The following is a description of a gene set: Genes correlated with the development of hyperglycemia in obese mice. from publication Nadler ST, Stoehr JP, Schueler KL, Tanimoto G, Yandell BS, Attie AD (PMID 11027337) species: Mus musculus Obesity is strongly correlated with type 2 diabetes mellitus, a common disorder of glucose and lipid metabolism. Although adipocytes are critical in obesity, their role in diabetes has only recently been appreciated. We conducted studies by using DNA microarrays to identify differences in gene expression in adipose tissue from lean, obese, and obese-diabetic mice. The expression level of over 11,000 transcripts was analyzed, and 214 transcripts showed significant differences between lean and obese mice. Surprisingly, the expression of genes normally associated with adipocyte differentiation were down-regulated in obesity. Not all obese individuals will become diabetic; many remain normoglycemic despite profound obesity. Understanding the transition to obesity with concomitant diabetes will provide important clues to the pathogenesis of type 2 diabetes. Therefore, we examined the levels of gene expression in adipose tissue from five groups of obese mice with varying degrees of hyperglycemia, and we identified genes whose expression strongly correlated with diabetes severity. This group included many genes that are known to be involved in signal transduction and energy metabolism as well as genes not previously examined in the context of diabetes. Our data show that a decrease in expression of genes normally involved in adipogenesis is associated with obesity, and we further identify genes important for subsequent development of type 2 diabetes mellitus. Human Gene Set: NADLER_HYPERGLYCEMIA_AT_OBESITY, and this is the list of marker genes: SNRPB, HPS4, DLX5, DNAJB12, CSF2RB, CCT4, ACP5, NPTX1, POLR1E, NDUFB3, ADRB3, RRAS2, ALDH7A1, TUBGCP4, SERPINE1 (NCBI Gene Id 5054), FLT3, UBE2E3, PTPN18, POLR2H, DVL3, ACYP2, RPS27, PPP1R2, SORBS3, CLTB, DYNLT1, BACH1, DHPS, GAP43, HPS1, SELENOW, FOXD1, HR, ACADL, BTG3, PDE1B, SUB1, GTF2H1, VAV1, CACNA1S, FCGR2B (Fc gamma receptor IIb), OGG1, VPS26C, TUBB4B, RNASEH2A, GUCA2A, CISH, CRELD2, SERPINH1, MRPS18B, TUBGCP3, UTP4, WNT1, FYN, SERPINA1, RENBP, MKRN2, PABPN1